The following is a description of a gene set: Human Gene Set: HP_CONGENITAL_LOCALIZED_ABSENCE_OF_SKIN Congenital localized absence of skin species: Homo sapiens, and this is the list of marker genes: LAMA3, LAMB3, LAMC2, DLL4, ITGB4, BMS1, PLEC, COL7A1, UBA2